The following is a description of a gene set: part of: SARS-CoV-1-host interactions species: Homo sapiens PDZ domains are protein‑protein recognition sequences, consisting of 80–90 amino acids that bind to a PDZ‑binding motif (PBM), usually located at the carboxy‑terminus of a target protein (Hung AY & Sheng M 2002; Gerek ZN et al. 2009; Munz M et al. 2012). Proteins containing PDZ domains are typically found in the cell cytoplasm or in association with the plasma membrane and play a role in cell‑cell junction formation, establishment of cellular polarity, and signal transduction pathways. The multidomain structure of PDZ-containing proteins enables them to interact with multiple binding partners simultaneously, thereby assembling larger protein complexes (Harris BZ & Lim WA 2001). Viruses also encode PBM-containing proteins that bind to cellular PDZ proteins. Viral PBMs target cellular PDZ-containing proteins involved in tight junction formation, cell polarity establishment, and apoptosis (Javier RT & Rice AP 2011). Reactome Pathway: SARS-CoV-1 targets PDZ proteins in cell-cell junction, and this is the list of marker genes: E, PALS1